Given this list of marker genes OPCML, PDE6A, RANBP6, EPHA7, TTK, LEMD3, CXCL8, DIAPH1, IPMK, NAALADL2, CADPS2 (calcium dependent secretion activator 2), FAM98A, SMAD5, MCTP1, PCDH11X, LYRM7, CYP11B1, FAM168A, JAG1, P2RY14, ACVR1, CASK, TRMT11, CIAO2A, MTUS1, DYNC1I1, C1GALT1, DENND1B, ADAMTS8, RGS5, PCDH11Y, SERINC1, PCSK6, ANGPTL5, DOCK5, RAG2, VEPH1, MATR3, PSIP1 (NCBI Gene Id 93428), TSHR, CGRRF1, HOXA9, TMSB4Y, SDE2, SAMD5, HOXA13, CAPZB, COX20, NUTF2, ACER3, NEGR1, TMED7, FMNL2, HTR2C, GALNT11, RCHY1, PDS5B, BMP6, NKAIN2, SLC6A15, PHYHIPL, SP4, ADGRF1, WASHC4, SLC35A3, PDLIM5, here is a description of the gene set: Human Gene Set: MIR376A_2_5P from publication Chen Y, Wang X (PMID 31504780) species: Homo sapiens Genes predicted to be targets of miRBase v22 microRNA hsa-miR-376a-2-5p in miRDB v6.0 with MirTarget v4 prediction scores > 80 (high confidence targets).